The following is a description of a gene set: Human Gene Set: GOBP_AMACRINE_CELL_DIFFERENTIATION The process in which a relatively unspecialized cell acquires specialized features of an amacrine cell, an interneuron generated in the inner nuclear layer (INL) of the vertebrate retina. Amacrine cells integrate, modulate, and interpose a temporal domain in the visual message presented to the retinal ganglion cells, with which they synapse in the inner plexiform layer. Amacrine cells lack large axons. studied in species Homo sapiens, and this is the list of marker genes: POU4F2, TGIF1, TGIF2, DLX2, PTF1A, NEUROD4, HES1, RORB, DLX1, GDF11, NEUROD1 (neuronal differentiation 1), BARHL2, FOXN4